The following is a description of a gene set: The gene expression profile of peripheral Foxp3+ natural regulatory T cells isolated from Foxp3/EGFP bicistronic mice was compared to that of in vitro-induced regulatory T cells and to CD4+ conventional (Foxp3-) T cells. The role of the regulatory T cell transcription factor Foxp3 in shaping the transcriptosomes of natural and induced regulatory T cells was analyzed using mice expressing a mutant FOXP3-EGFP fusion protein (Foxp3deltaEGFP). We used gene expression microarrays to examine the transcriptional programs of natural and induced regulatory T cells and the function of Foxp3 in organizing the transcriptosomes of the respective cell type from publication Haribhai D, Lin W, Edwards B, Ziegelbauer J, Salzman NH, Carlson MR, Li SH, Simpson PM, Chatila TA, Williams CB (PMID 19265124) studied in species Homo sapiens Human Gene Set: GSE14415_ACT_VS_CTRL_NATURAL_TREG_UP Genes up-regulated in natural T reg: activated versus naïve., and this is the list of marker genes: HLA-B, CYP20A1, RFC5, BIRC5, LSM7, MORF4L2, CLTB, EXOC8, CDK4, RNPS1, C1orf35, CYP26B1, PGAM1, TAGLN2, CARS1, EEF1E1, ISOC1, CASP1, LDHA, BUB3, TTC8, NAT8, PSMG2, H1-1, TMEM106A, UMPS, RPL7L1, SPIRE1, CSF3R, NEFH, CRELD2, NEUROD1, MTO1, CDK1, PRELID2, MED30, FADD, PLD5, UCK2, PSMD6, LSM3, ZFP41 (NCBI Gene Id 89856), MSMO1, CMAHP, TAF12, SGO1, LSM10, TMCC3, SNRPA1, MRPS25, MRPS18B, MAPK8IP1, PCBP1, TUBB4B, POLD1, ERG28, PDE6D, SLC35C1, MDH2, DLAT, DDX18, CENPS, MRPS18A, H4C9, SCARB1, CHID1, NUP37, SF3B6, ARL3, RRM2, PBDC1, GJA8, GEMIN6, POLG, NDUFAF1, MDC1, PSMB2, CDC20, MRPL1, CKS2, TNFSF10, ORC6, GZMK, NIP7, PCTP, ERP29, GRK3, NIPSNAP3B, CHRNA5, TTC9C, IL1B, SIVA1, XRCC1, TMEM107, RSU1, CISD1, ACOT11, PRMT5, H2BC26, RHBDD3, OMA1, ZC3H18, BEX3, FLNB, RANBP1, TEX30, GINS1, POLR3K, TIMM17A, FAM72A, GLO1, CAB39L, ATP6V0E1, POLR2L, TUBA4A, ZBTB32, SCYL1, POLE2, CD48, CDCA3, MRPL49, LSM12, PCLAF, LYAR, GLRX3 (NCBI Gene Id 414229), DNPH1, VDAC3, C1QBP, ASF1B, MXD3, FBXO5, UROS, NME1, CEP20, CPM, ADRB3, KPNA2, AURKA, EEF1D, CYP39A1, KMT5A, MRPL22, PIH1D2 (NCBI Gene Id 120379), FCGRT, ACAT2, LSM2, SEC13, SPMAP1, UCHL3, ADSL, CINP, MRTO4, CCL2, METTL8, ALYREF, RAPSN, NHP2, PCNP, SFXN1 (sideroflexin 1), CARS2, CDR2, ZMAT1, KYAT3, NDUFAF6, MRPL18, UBE2I, TLCD5, RPA3, TFDP1, MAFF, HIRIP3, NDUFAF2, MARS1, TSPAN32, TRIR, COX19, ZFYVE27, ING1, TRMT2A, RPAIN, PBK, DCK, RBBP7